Given this list of marker genes SCARB1, FABP5, TALDO1, AQP7, OR2H2, ACSL1 (acyl-CoA synthetase long chain family member 1), CEBPA, CIDEC, SORBS1, RASD1, DGAT1, STAT1, PCK1, LAMA4, QKI (NCBI Gene Id 9444), DHRS3, HIPK3, NFS1, ARL4A, DBI, ACOX1, HIPK2, PLIN4, HSD17B4, here is a description of the gene set: species: Mus musculus Human Gene Set: RUAN_RESPONSE_TO_TROGLITAZONE_UP Troglitazone (TGZ), a member of the thiazolidinedione class of anti-diabetic compounds and a peroxisome proliferator activator receptor-gamma (PPAR-gamma) agonist, restores systemic insulin sensitivity and improves the full insulin resistance syndrome in vivo. The mechanisms underlying its in vivo function are not understood. Here we investigated the potential functional interaction between PPAR-gamma and NF-kappaB in adipocytes. We show that TGZ selectively blocked tumor necrosis factor-alpha-induced and NF-kappaB-dependent repression of multiple adipocyte-specific genes and induction of growth phase and other genes. This occurs without interfering with NF-kappaB expression, activation, nuclear translocation, or DNA binding and without suppressing NF-kappaB-dependent survival signals. Notably, the expressions of some tumor necrosis factor-alpha-induced genes in adipocytes were unaffected by PPAR-gamma activation. In reporter gene assays in HeLa cells, ectopic expression of PPAR-gamma abolished induction of a NF-kappaB-responsive reporter gene by the p65 subunit (RelA) of NF-kappaB, and the inhibition was further enhanced in the presence of TGZ. Conversely, overexpression of p65 inhibited induction of a PPAR-gamma-responsive reporter gene by activated PPAR-gamma in a dose-dependent manner. The inhibitory effect was independent of the presence of NF-kappaB-binding sites in the promoter region. Other NF-kappaB family members, p50 and c-Rel as well as the S276A mutant of p65, blocked PPAR-gamma-mediated gene transcription less effectively. Thus, p65 antagonizes the transcriptional regulatory activity of PPAR-gamma in adipocytes, and PPAR-gamma activation can at least partially override the inhibitory effects of p65 on the expression of key adipocyte genes. Our data suggest that inhibition of NF-kappaB activity is a mechanism by which PPAR-gamma agonists improve insulin sensitivity in vivo and that adipocyte NF-kappaB is a potential therapeutic target for obesity-linked type 2 diabetes. Adipocyte abundant genes up-regulated in 3T3-L1 cells (fibroblasts induced to differentiate to adipocytes) in response to troglitazone. from publication Ruan H, Pownall HJ, Lodish HF (PMID 12732648)